Given this list of marker genes Ruvbl2, Actr5, Ino80e, Actl6a, Actr8, Mcrs1, Tfpt, Yy1, Ino80, Gon4l, Ino80c, Ino80d, Uchl5, Nfrkb, Ruvbl1, Ino80b, here is a description of the gene set: Mouse Gene Set: GOCC_INO80_COMPLEX A multisubunit protein complex that contains the Ino80p ATPase; exhibits chromatin remodeling activity. species: Mus musculus